Given this list of marker genes Epm2a, Plod3, Uggt1, Gys1, Poglut3, Gyg1, Gba2, Gys2, Gba1, Alg10b, Alg6, Alg8, Ugt8a, Alg5, Ugcg, Uggt2, Poglut1, Poglut2, here is a description of the gene set: studied in species Mus musculus Catalysis of the transfer of a glucosyl group to an acceptor molecule, typically another carbohydrate or a lipid. Mouse Gene Set: GOMF_GLUCOSYLTRANSFERASE_ACTIVITY